Given this list of marker genes Borcs5, Bloc1s2, Borcs6, Borcs8, Bloc1s1, Borcs7, Snapin, Kxd1, here is a description of the gene set: Mouse Gene Set: GOCC_BORC_COMPLEX species: Mus musculus A protein complex that is involved in positioning of the lysosome within the cytoplasm and which is composed of BLOC1S1, BLOC1S2, BORCS5, BORCS6, BORCS7, BORCS8, KXD1 and SNAPIN. The BORC complex recruits ARL8 at the cytosolic face of lysosomes and couples them to microtubule plus-end-directed kinesin motors.